The following is a description of a gene set: studied in species Homo sapiens Neighborhood of MAP2K2 mitogen-activated protein kinase kinase 2 in the MORF expression compendium Human Gene Set: MORF_MAP2K2 Neighborhood of MAP2K2, and this is the list of marker genes: ERP29, VDAC3, VPS26A, FAM120A, CCT5, PSMD8, DCTN2, PSMB2, AKR7A2, HAX1, PARK7, NONO, KHDRBS1, YWHAQ, CCT7, TMEM147, HADHB (NCBI Gene Id 3032), HNRNPUL1, U2AF1, PTDSS1, GNB2, IFRD1, SF3B2, GNB1, AFG3L2, NDUFS5, MRPS18B, GANAB, HCCS (holocytochrome c synthase), MTA1, DDX49, PPT1, LSM4, LYPLA1, TRIM28, MRPL9, SLC25A3, PPP2R1A, NRDC, RUVBL2, COX5B, EIF4EBP2, PSMB7, JTB, TUFM, MTDH, BCAP31, TRAPPC3, RANGAP1, ANAPC5, COPS5, TMED9 (transmembrane p24 trafficking protein 9), TBL3, BANF1, POLR2I, EIF3I, IDH3G, DDOST (dolichyl-diphosphooligosaccharide--protein glycosyltransferase non-catalytic subunit), IDH3B, LSM2, HADHA, ATP5PO, KARS1, GPI, IMPDH1, TCEA1, NDUFS3, HNRNPAB, RHEB, CSNK2B, BUB3, UBE2S, COX8A, EIF3K, GNG5, CYC1, MTCP1, PCMT1, SET, SLC3A2, SNRNP200, VDAC2, DGKZ, AP2S1, ATP5F1D, GPX4, SNRPA, MYDGF, ATXN10, KXD1, PPM1G, SNRPE, CYCS, PUF60, STARD7, CS, AP3D1, PRPF31, PDHB, ATP5MC3, XPO7, HDAC2, CAPZA1, RAD23A, ATP6AP1, DRG1, SRSF9, CTDNEP1, PRDX3, RPN1, AP3S1, MDH1, FIBP, GPAA1, SDHB, H2AZ1, SLC4A2, SSBP1, NDUFV1, CANX, NUP188, MAP2K2, SOD1, SDHA, RNPEP, RAC1, GLB1, COPE, NSDHL, NDUFC1, ZNRD2, AP2M1